Given this list of marker genes MYOD1, IFRD1, PITX1, TCF7L2, EPAS1, ITGB1, here is a description of the gene set: species: Homo sapiens Human Gene Set: GOBP_MYOBLAST_FATE_COMMITMENT The process in which the developmental fate of a cell becomes restricted such that it will develop into a myoblast. A myoblast is a mononucleate cell type that, by fusion with other myoblasts, gives rise to the myotubes that eventually develop into skeletal muscle fibers.